The following is a description of a gene set: Enables the transfer of taurine from one side of a membrane to the other. Taurine (2-aminoethanesulfonic acid) is a sulphur-containing amino acid derivative which is important in the metabolism of fats. studied in species Mus musculus Mouse Gene Set: GOMF_TAURINE_TRANSMEMBRANE_TRANSPORTER_ACTIVITY, and this is the list of marker genes: Slc36a1, Slc6a6, Slc16a6, Slc6a13, Slc6a11